The following is a description of a gene set: species: Homo sapiens The process in which outgrowths develop from the shafts of existing axons. Human Gene Set: GOBP_COLLATERAL_SPROUTING, and this is the list of marker genes: DCC, NGF, BDNF (NCBI Gene Id 627), LPAR3, PTPRS, SPART, WNT3A, SEMA4D, COBL, HDAC6, WNT3, RND2, EPHA7, BCL11A, IFRD1, EFNA5 (ephrin A5), DVL1, APP, CRABP2, ULK2, FGF13, FSTL4, NPR2, NIN, SPP1, SPG21, ZEB2, IST1, ULK1, CD2AP, RGMA (NCBI Gene Id 56963), PRKG1